Given this list of marker genes MTG2, RCC1L, MTG1, MIURF, DHX30, FASTKD2, MRM2, DDX28, here is a description of the gene set: The aggregation, arrangement and bonding together of a set of components to form a mitochondrial large ribosomal subunit. Human Gene Set: GOBP_MITOCHONDRIAL_LARGE_RIBOSOMAL_SUBUNIT_ASSEMBLY species: Homo sapiens